The following is a description of a gene set: Mouse Gene Set: GOCC_MYELIN_SHEATH An electrically insulating fatty layer that surrounds the axons of many neurons. It is an outgrowth of glial cells: Schwann cells supply the myelin for peripheral neurons while oligodendrocytes supply it to those of the central nervous system. species: Mus musculus, and this is the list of marker genes: Nefm, Rap1a, Dld, Sptan1, Hbb-bs, Septin8, Pard3, Ndufs3, Cltc, Cox6a1 (NCBI Gene Id 12861), Actg1, Hspa8, Slc25a3, Akr1b1, Cdh1, Atp5f1c, Erbb2, Eef1a2, Pmp2, Myoc, Tppp (tubulin polymerization promoting protein), Dpysl2, Mag, Slc25a4, Cldn11, Idh3a, Phgdh, Nme2, Atp1a1, Pitpna, Arf6, Tagln3, Uqcrc1, Hba-a1 (NCBI Gene Id 15122), Immt, Ndrg1, Napb, Prxl2b, Cdc42, Pkm, Cntn1, Exoc4, Gpm6b, Cntn2, Cnp (2',3'-cyclic nucleotide 3' phosphodiesterase), Ncam1, Gnb5, Tubb4b, Sirt2, Ubc, Dlat, Atp1b1, Tkt, Actr1a (NCBI Gene Id 54130), Thy1, Llgl1, Ndufv2, Sucla2, Got2, Igsf8, Ldhb, Ass1, Mdh2, Dnm1, Vdac1, Nme1 (NCBI Gene Id 18102), Ermn, Tuba1a, Phb1, Rdx, Eef1a1, Wdr1, Fscn1, Gdi2, Slc25a12, Uqcrc2, Septin7 (septin 7), Gnb4, Cldn5, Syn1, Prkcz, Cox5b, Cldn19, Uchl1, Dlst, Mal, Prkci, Atp5f1b, Sod2, Gpi1, Gnb1, Septin4, Atp5pd, Hspa5, Uba52, Scrib, Ndufa10, Stip1, Clcn2, Bcl2, Pgam1, Gfap (glial fibrillary acidic protein), Jam3, Sod1, Cct3, Cd59b, Tspan2, Pdha1, Nsf, Gjc3, Serinc5, Myo1d, Hspa9, Atp1a2, Pebp1, Pdcd6ip, Car13, Cryab, Prdx2 (peroxiredoxin 2), Tuba1b, Ppia, Stx4a, Mif, Mpdz, Aco2, Calml3 (NCBI Gene Id 70405), Vdac2, Eno1, Cd59a, Ckmt1, Hspa2, Ncmap, Plec, Gjc2, Plp1, Ehd1, Actb, Glul, Nfasc, Alb, Napa, Ubb (NCBI Gene Id 22187), Cox5a, Nefh, Snap25, Septin2, Aldoa, Sdha, Pacsin1, Slc25a5 (NCBI Gene Id 11740), Uqcrfs1, Tufm, Atp5pb, Cnrip1, Pmp22, Mobp, Tubb4a, Napg, Hspd1, Eno2, Calm1, Rps27a, Gnao1, Stxbp1 (syntaxin binding protein 1), Msn, Calm2, Gnb2 (guanine nucleotide binding protein (G protein), beta 2), Myh14, Ina, Pals1, Ehd3, Canx, Vcp, Cct5, Mdh1, Plcb1, Anxa2, Atp6v1a, Pdia3, Cycs, Nefl, Gapdh, Hsp90aa1, Rala, Pten, Tcp1 (NCBI Gene Id 435546), Atp6v1b2, Marveld2, Ywhag, Atp5po, Car2, Gstm1, Mbp, Ckb (NCBI Gene Id 12709), Mog, Atp1a3 (ATPase, Na+/K+ transporting, alpha 3 polypeptide), Syn2, Ndufs1, Pllp, Cct2, Omg, Ezr, Dlg1, Gsn, Prdx1, Itgb1, Gdi1, Cntnap1, Prdx3, Atp5f1a, Calm3